The following is a description of a gene set: Human Gene Set: GRABARCZYK_BCL11B_TARGETS_UP from publication Grabarczyk P, Przybylski GK, Depke M, Völker U, Bahr J, Assmus K, Bröker BM, Walther R, Schmidt CA (PMID 17173069) species: Homo sapiens Genes up-regulated in Jurkat cells (transformed T lymphocytes) after knockdown of BCL11B by RNAi. The B-cell chronic lymphocytic leukemia (CLL)/lymphoma 11B gene (BCL11B) encodes a Krüppel-like zinc-finger protein, which plays a crucial role in thymopoiesis and has been associated with hematopoietic malignancies. It was hypothesized that BCL11B may act as a tumor-suppressor gene, but its precise function has not yet been elucidated. Here, we demonstrate that the survival of human T-cell leukemia and lymphoma cell lines is critically dependent on Bcl11b. Suppression of Bcl11b by RNA interference selectively induced apoptosis in transformed T cells whereas normal mature T cells remained unaffected. The apoptosis was effected by simultaneous activation of death receptor-mediated and intrinsic apoptotic pathways, most likely as a result of tumor necrosis factor-related apoptosis-inducing ligand (TRAIL) upregulation and suppression of the Bcl-xL antiapoptotic protein. Our data indicate an antiapoptotic function of Bcl11b. The resistance of normal mature T lymphocytes to Bcl11b suppression-induced apoptosis and restricted expression pattern make it an attractive therapeutic target in T-cell malignancies., and this is the list of marker genes: IKZF2, BICD2, PMP22, ZNF814, JAK1, RDX, RPS6KA3, ID1, MREG, U2AF1, TRGC1, TMEM167A, TRAM2, NUS1, SCARB2, IGLL3P, PAFAH1B2, SH3BP5, CAMSAP2, BNIP3, IL2RB, TIMP1, SPOPL, IGLC2, USO1, SLC35F5, NEK7, AASDHPPT, APOBEC3G, ANKRD46, ZNF678, PPIP5K2, PRKCQ-AS1, MAPK6, TPRG1L, CRYBG1, GMFB, PLEKHA8 (pleckstrin homology domain containing A8), NKG7, ACACA, AGPS, MYCN, USP44, SLC30A9, DENND1B, ZBTB16, TNFSF10 (NCBI Gene Id 8743), UMAD1, STING1, PIK3R1, AK4, ATP5F1E, ZDHHC21 (zinc finger DHHC-type palmitoyltransferase 21), ANXA2, STK26, CTSW, SLC35A1, SNHG33 (small nucleolar RNA host gene 33), CCSER2, PIK3R3, ADCYAP1, S100A4, MSI2, NQO1, ITGB7, PDCD6IP, PRF1, TOR1AIP2, CCR7, ID2, LGALS1, ATP6V0E2, RECQL, GSAP, TRUB1, HSH2D, RAB27A, PEX26, PRKAR2B, AHNAK, CARINH